The following is a description of a gene set: species: Homo sapiens The change in form (cell shape and size) that occurs during the differentiation of an endothelial cell. Human Gene Set: GOBP_ENDOTHELIAL_CELL_MORPHOGENESIS, and this is the list of marker genes: PLOD3 (NCBI Gene Id 8985), HOXA13, CDH5, ARHGEF26, AMOTL2, MAGI1, STC1, HEG1, CLIC4, TNMD, NOTCH4, MET, COL18A1, PECAM1, ID1